Given this list of marker genes HES7 (NCBI Gene Id 84667), APBB1, ARK2C, CADM3, WNT9B, ASB6, TEF, ADAR, NRSN2, AMBRA1, OTUD5, CALM3, G3BP2, LHX6, RNPEPL1, TMEM150A, NFATC2, NCS1, SLC52A3, GLP1R, PACS1, ATXN7L3, ODC1, FOXP4, MFSD12, DMTN, TMEM68, ARB2A, RPUSD1, OBSL1, CELSR2, SLC6A9, CLDN23, RAC2, PYGB, FRMD3, MICALL1, ZNF500, SHANK1, TRABD2B, RAD9B, C1QTNF6, ATG4D, CELF5, ATP10B, BAP1, CDC42SE1, DLGAP3, DOLPP1, RFFL, SNX19, CPEB1, NNAT, PNKD, CLCN4, ARPC5, RGMA, NEXMIF, UBE2O, PHOSPHO1, ZNF608, LNPK, MAP1LC3A, TMEM184B, NECTIN1, FAM222B, LZTS3, ENC1 (ectodermal-neural cortex 1), CXCL16, SELENON, CRIP3, SOX12, MED28, COL1A1, COPS7B, LRRC47, ERI3, KASH5, DUSP8, HIC2, BCORL1, SCN4A, TEC, TCL1B, DNALI1, STK40, EVC, DMWD, S100A16, FBXL16, ROR2, PAQR8, GRM4, ACAP3, TMEM41A, NFIC, TSPAN11, NAV1, PDXP, ADGRL1, RIMS4, ARHGEF4, PLEKHO1, CBX6, MUL1, KDM5B, CIMAP1C, SYP (NCBI Gene Id 6855), LASP1, PLA2G6, SEPTIN9, ENSG00000187186 (NCBI Gene Id 731532), KCNIP3, MAPKBP1, ABCC5, NAT8L, SLC20A2 (solute carrier family 20 member 2), SAMD4B, ST6GALNAC6, ELFN2, KLK4, PGRMC2, DISC1, SUFU, ASB14, SDR16C5, BEND3, DAP, HDDC3, DDX54, PLCB1, ADISSP, SCAF1, MKRN2, PDAP1, STK24, NACC1, CSMD2, SLC11A2, ELF4, here is a description of the gene set: from publication Chen Y, Wang X (PMID 31504780) Human Gene Set: MIR423_5P Genes predicted to be targets of miRBase v22 microRNA hsa-miR-423-5p in miRDB v6.0 with MirTarget v4 prediction scores > 80 (high confidence targets). species: Homo sapiens